The following is a description of a gene set: Mouse Gene Set: REACTOME_SHC_RELATED_EVENTS_TRIGGERED_BY_IGF1R SHC-related events triggered by IGF1R species: Mus musculus, and this is the list of marker genes: Sos1, Igf1, Igf2, Shc1, Grb2, Igf1r